Given this list of marker genes POLD3, WRN, PMS2P5, HDAC10, MCM9 (NCBI Gene Id 54844), PMS1, MUTYH, PMS2P1, TP73, MCM8, PCNA, LIG1, PRKCG, RNASEH2B, PMS2P6, MSH6, RNASEH2A, TREX1, XPC, RPA3, MSH5, ABL1, EXO1, MSH4, PMS2, SETD2, RPA1, MSH2, MLH1 (mutL homolog 1), MSH3, HMGB1, RPA2, RNASEH2C, AXIN2, MLH3, PMS2P3 (PMS1 homolog 2, mismatch repair system component pseudogene 3), here is a description of the gene set: studied in species Homo sapiens A system for the correction of errors in which an incorrect base, which cannot form hydrogen bonds with the corresponding base in the parent strand, is incorporated into the daughter strand. The mismatch repair system promotes genomic fidelity by repairing base-base mismatches, insertion-deletion loops and heterologies generated during DNA replication and recombination. Human Gene Set: GOBP_MISMATCH_REPAIR